The following is a description of a gene set: part of: Developmental Biology species: Homo sapiens Reactome Pathway: Developmental Cell Lineages Our bodies are built of >30 trillion cells specialized to fulfill diverse roles within our tissues, organs, and organ systems. All these cells originate from a single cell, a zygote formed at conception. From zygote to fetus, and throughout childhood, adolescence, and adulthood, cells divide and commit to different fates in order for the organism to develop, sustain and regenerate. The series of steps that lead from an undifferentiated progenitor cell, such as a stem cell, to one of its several possible specialized descendants constitutes a cell lineage path. Cell lineage paths are organized by organ systems. Each cell lineage path cross-references a Gene Ontology (GO) biological process (The Gene Ontology Consortium 2019), and consists of a series of causally connected cell development steps. Cell development steps describe the transition between cell states during development or differentiation and are characterized by regulators (molecules promoting or inhibiting the step) and, when established, “required input components” (cell state biomarkers required for the action of regulators). Each cell state is characterized by a cell type defined in Cell Ontology, anatomical location from UBERON, and a unique combination of protein and/or RNA markers with references, when available, to CellMarker and PanglaoDB. For a more detailed data model description, please refer to Milacic et al. 2024. Recent technological advances have allowed researchers to harvest high-throughput omics data from single cells of multicellular organisms and use it to track and manipulate cell fates. This opens the door to the possibility of deciphering cell lineage paths at single-cell resolution, a critical requirement for the advancement of regenerative medicine and cancer medicine.<br><br>The cell lineage path “Differentiation of keratinocytes in interfollicular epidermis in mammalian skin” describes the differentiation of keratinocytes from stem cells to corneocytes in the interfollicular epidermis, the skin surface layer in between the adnexa (hair follicles, sweat glands, and sebaceous glands)., and this is the list of marker genes: LAMB3, VTN, LAMA4, COL5A1 (NCBI Gene Id 1289), COL1A2, COL27A1, COL11A1, LAMC1, COL3A1, COL11A2, EGF, COL5A3, TGFA, COL24A1, FGF4, FN1, AREG, FGF2, LAMA2, LAMC2, LAMC3, COL1A1, COL2A1, FGF10, LAMB2, LAMA3, PRL, LAMB1, LAMA1, LAMA5, FGF7, COL5A2